The following is a description of a gene set: Neighborhood of BECN1 Neighborhood of BECN1 beclin 1 (coiled-coil, myosin-like BCL2 interacting protein) in the GCM expression compendium studied in species Homo sapiens Human Gene Set: GCM_BECN1, and this is the list of marker genes: ZNF8, USP7, MIEF1, CMTR1, GCGR, ARHGDIA, SDHC, ESD, PSMD6, CCNI, TLK2, BECN1, BCLAF1 (NCBI Gene Id 9774), DGCR6, RING1, IKBKE, FCGR2B (Fc gamma receptor IIb), SP2, UFD1, FANCC, SRSF4, ADRB3, PNMT, ATP5MC1, TAX1BP1, NQO2, CHKB, IDUA, GRM4, ATP5PB, BCAT2, PLK1, UPF1, RSU1, CHMP1A, AQP2 (NCBI Gene Id 359), UBAP2L, VPS72, NEFL, PCK2, SLC25A3, HTT (huntingtin), FUS, DRG2, MAPRE1, UBE2D3, RNPS1, DAZAP2, SMG7, TIMM17A, NUP188, CYTH2, MPP2, TTC1, SKP1, HNRNPM, GPER1, SLC2A4, PSMB6, PMS2P11, MAPK3, NDUFA12, EIF4H, RENBP, ARF1 (NCBI Gene Id 375, ADP ribosylation factor 1), RABGGTA, AAMP, GSTZ1